The following is a description of a gene set: Human Gene Set: MIKHAYLOVA_OXIDATIVE_STRESS_RESPONSE_VIA_VHL_UP Human renal clear cell carcinoma (RCC) is frequently associated with loss of the von Hippel-Lindau (VHL) tumor suppressor (pVHL), which inhibits ubiquitylation and degradation of the alpha subunits of hypoxia-inducible transcription factor. pVHL also ubiquitylates the large subunit of RNA polymerase II, Rpb1, phosphorylated on serine 5 (Ser5) within the C-terminal domain (CTD). A hydroxylated proline 1465 within an LXXLAP motif located N-terminal to the CTD allows the interaction of Rpb1 with pVHL. Here we report that in RCC cells, pVHL regulates expression of Rpb1 and is necessary for low-grade oxidative-stress-induced recruitment of Rpb1 to the DNA-engaged fraction and for its P1465 hydroxylation, phosphorylation, and nondegradative ubiquitylation. Egln-9-type prolyl hydroxylases, PHD1 and PHD2, coimmunoprecipitated with Rpb1 in the chromatin fraction of VHL(+) RCC cells in response to oxidative stress, and PHD1 was necessary for P1465 hydroxylation while PHD2 had an inhibitory effect. P1465 hydroxylation was required for oxidative-stress-induced Ser5 phosphorylation of Rpb1. Importantly, overexpression of wild-type Rpb1 stimulated formation of kidney tumors by VHL(+) cells, and this effect was abolished by P1465A mutation of Rpb1. These data indicate that through this novel pathway involving P1465 hydroxylation and Ser5 phosphorylation of Rbp1, pVHL may regulate tumor growth. from publication Mikhaylova O, Ignacak ML, Barankiewicz TJ, Harbaugh SV, Yi Y, Maxwell PH, Schneider M, Van Geyte K, Carmeliet P, Revelo MP, Wyder M, Greis KD, Meller J, Czyzyk-Krzeska MF (PMID 18285459) studied in species Homo sapiens Proteins significantly induced by oxidative stress (hydrogen peroxide in 786-O cells (renal clear cell carcinoma, RCC) expressing VHL., and this is the list of marker genes: HYOU1, VIM, DCTN2, EIF5A, CAPRIN1, CLIC1, ATP5F1B